Given this list of marker genes Zswim6, Zfpm2, Dse, Sar1a, Brdt, Fgd1, Gprasp2, Bin3, Gnal, Yy1, here is a description of the gene set: from publication Chen Y, Wang X (PMID 31504780) Mouse Gene Set: MIR_7029_5P studied in species Mus musculus Genes predicted to be targets of miRBase v22 microRNA mmu_miR_7029_5p in miRDB v6.0 with MirTarget v4 prediction scores > 80 (high confidence targets).